The following is a description of a gene set: Human Gene Set: GOBP_L_SERINE_CATABOLIC_PROCESS The chemical reactions and pathways resulting in the breakdown of L-serine, the L-enantiomer of serine, i.e. (2S)-2-amino-3-hydroxypropanoic acid. studied in species Homo sapiens, and this is the list of marker genes: CBS, ENSG00000274276, SHMT1, SDS, SDSL